The following is a description of a gene set: A protein complex that functions in the retrotranslocation step of ERAD (ER-associated protein degradation), and includes at its core Derlin-1 oligomers forming a retrotranslocation channel. studied in species Mus musculus Mouse Gene Set: GOCC_DERLIN_1_RETROTRANSLOCATION_COMPLEX, and this is the list of marker genes: Syvn1, Rnf139, Selenos, Sel1l, Derl1, Amfr, Vcp, H13